Given this list of marker genes ATRX, C1R, DDB2, CHUK, DDR2, COL3A1, SMAD2, EDARADD, ORC1 (origin recognition complex subunit 1), PRKAR1A, USP8, TGFB2, FLNA, COL1A1, EDAR, GNAS, PEPD, SLC2A10, ADAMTS2, ALDH18A1, TRAF6, ABL1, PRKD1, WNT10A, ERCC3, ADAMTSL2, CAV1 (NCBI Gene Id 857), PTDSS1, BRAF, XPA, SMAD3, UBE3B, IFT140, MTAP, RECQL, ARF1, ERMARD, TP63, ERCC2, PIK3R1, FMR1, TP53, SLC39A13, SOX18, TGFBR2, DHX30, ERCC5, SMARCAD1, XPC, LMNA, ARFGEF2, EDA, ZMPSTE24, KDF1, POLR3A, NR3C1, TGFB3, CDH23, GORAB, PPP1CB, LIFR, ERCC4, ADNP, PYCR1, B3GALT6, IPO8, PLOD1, MAP1B, PORCN, COL1A2, COL7A1, TMTC3, TWIST2, PDE11A, PROS1, RBCK1, CTC1, PPARG, B4GALT7, NFIX, TNXB, TGFBR1, USP48, EFEMP1, NEDD4L, PROC, SATB2, PDGFRB, KRT2, AIP, here is a description of the gene set: Thin skin studied in species Homo sapiens Human Gene Set: HP_THIN_SKIN Reduction in thickness of the skin, generally associated with a loss of suppleness and elasticity of the skin.